Given this list of marker genes FEN1, UBE2C, CENPA, HNRNPAB, LBHD1, MCM4, PRKCB, COG4, KIF22, KNTC1, SPRR3, ZWILCH, CSTF2, MYB, MED20, ABTB2, IGHM, DUT, TPGS2, PLPP1, DUSP4, PCLAF, EIF4EBP2, TK1, NTRK1 (NCBI Gene Id 7825), TRIP13, CCNA2, DHFR, CENPF, ELOVL6, PPIL2, SPAG5, CDC25B, EZH2, CNTFR, COX10, DEFB126, DCLRE1A, DTL, IL2RA, RAD1, CDC20, ITM2A, MCM2, GATA3, IL32, FIRRM, DLGAP5, FANCG (NCBI Gene Id 82603), GPR19, LANCL2, NELFE, SYT11, IL18R1, CDCA8, RPL39L, PPCDC, CDT1, UBFD1 (NCBI Gene Id 56061), DDX49, ZMYND10, KIF4A, NTN3 (NCBI Gene Id 4917), KIF11, SLC35F2 (NCBI Gene Id 79593), SEC61A2, CTPS2, RBBP8, IL9R, PTPRN2, AURKB, SP140, BUB1, AGK, FGFR1, GINS1, HJURP, AURKA, FANCI, CENPN, RAD51, CD79B, NSD2 (NCBI Gene Id 7468), KRT36, TRPA1 (NCBI Gene Id 8989), PLK4, UBE2S, INHBE, CASP9, TOP3A, MRPS11, PDZK1IP1, ATAD2, KIF15, MAOB, RPA3, CENPS, CDC7, LIG1, KLHL25, PTGDR2, PTPN22, WDHD1, CKS2, NCF4, TUBB3, NPDC1, PCNX1, FETUB, TUBB4B, BIRC5, CEP55, DAZAP1, KIF2C, RFC4, CDKN3, SNF8, NCAPG2, DPEP1, DLEU1, MELK, DONSON, GJC2, CDC14A, GGCX, ACTR1B, DDC, CBX5, DPP3, BLM, H4C3, ZBED2, UQCRQ, ASL, MRPS12, TRAC, GMNN, NDUFA7, FUT8 (NCBI Gene Id 2530), MCM7, DLEU2, GALK1, JPT1, IL2RB, ZNF544, ANXA6, CCDC51, RCC1, RRAS2, TMEM106C, P2RX5, ZWINT, SLCO4A1, CDC45, FIBP, TYMS, CENPM, TFDP1, TARS1, NUSAP1, CREM, CENPE, TOX4, CCR3, SLBP, IDH2, ITPR2, BRINP2, CORO1A, RRM2, RAC2, PCDHB11, SHMT2, CCNB1 (NCBI Gene Id 891), H2AX, MYBL2, PTTG1, TPX2, MRPL11, WDR76, CPN1, RNASEH2A, WHRN, BSPRY, RALGPS1, CKS1B, CCR8, PXMP2, RBM4B, EXO1, CD38, PSRC1 (NCBI Gene Id 96740), CCNB2 (NCBI Gene Id 9133), TNFSF10, PKP4, IRF4, PPP1R16B, LMNB1, EMC9, PRC1, here is a description of the gene set: Genes up-regulated in comparison of CD25+ regulatory T cell (Treg) treated with IL4 at day 7 versus CD25- T cells treated with IL4 at day 7. studied in species Homo sapiens Human Gene Set: GSE24634_TREG_VS_TCONV_POST_DAY7_IL4_CONVERSION_UP from publication Prots I, Skapenko A, Lipsky PE, Schulze-Koops H (PMID 21347372) CD25+ regulatory T cells develop in the thymus (nTregs), but may also be generated in the periphery upon stimulation of naive CD4 T cells under appropriate conditions (iTregs). The mechanisms that regulate the generation of peripheral iTregs are largely unknown. We used microarrays to gain insights into the molecular program of extrathymic Treg development.